Given this list of marker genes NRROS, ACVR1, WFIKKN1, TGFB3, TSKU, ENG, VASN, HYAL2, THBS1, LTBP1, LTBP3, LRRC32, CHRDL1, TGFBR2, LTBP4, ITGAV, TGFBR3L, LRG1, TGFBR1, TGFBR3, TWSG1, CD36, ACVRL1 (activin A receptor like type 1), WFIKKN2, here is a description of the gene set: Human Gene Set: GOMF_TRANSFORMING_GROWTH_FACTOR_BETA_BINDING species: Homo sapiens Binding to TGF-beta, transforming growth factor beta, a multifunctional peptide that controls proliferation, differentiation and other functions in many cell types.